The following is a description of a gene set: from publication Villanueva A, Hoshida Y, Battiston C, Tovar V, Sia D, Alsinet C, Cornella H, Liberzon A, Kobayashi M, Kumada H, Thung SN, Bruix J, Newell P, April C, Fan JB, Roayaie S, Mazzaferro V, Schwartz ME, Llovet JM (PMID 21320499) In approximately 70% of patients with hepatocellular carcinoma (HCC) treated by resection or ablation, disease recurs within 5 years. Although gene expression signatures have been associated with outcome, there is no method to predict recurrence based on combined clinical, pathology, and genomic data (from tumor and cirrhotic tissue). We evaluated gene expression signatures associated with outcome in a large cohort of patients with early stage (Barcelona-Clinic Liver Cancer 0/A), single-nodule HCC and heterogeneity of signatures within tumor tissues. Human Gene Set: ANDERSEN_LIVER_CANCER_KRT19_UP studied in species Homo sapiens Genes over-expressed in KRT19-positive hepatocellular carcinoma., and this is the list of marker genes: RPP21, CTSV, CSTB, YWHAQ, ARHGAP18, RPIA, KHDRBS1, DYNLT1, CBX3, RPS18, RPS14, RPL3, ZDHHC7, RPL27A, RPS12, RPL9, RPS3A, APEX1, CALM2, NCF2, IP6K2, ZSWIM1, RPS25, RPS17, RPL35A, CCT2, NOP58, POLR1H (RNA polymerase I subunit H), TES, RPL13A, RPL10A, EPCAM, MMP12, NAP1L1, CHKB